The following is a description of a gene set: Reactome Pathway: G2/M Checkpoints part of: Cell Cycle Checkpoints studied in species Homo sapiens G2/M checkpoints include the checks for damaged DNA, unreplicated DNA, and checks that ensure that the genome is replicated once and only once per cell cycle. If cells pass these checkpoints, they follow normal transition to the M phase. However, if any of these checkpoints fail, mitotic entry is prevented by specific G2/M checkpoint events.<p>The G2/M checkpoints can fail due to the presence of unreplicated DNA or damaged DNA. In such instances, the cyclin-dependent kinase, Cdc2(Cdk1), is maintained in its inactive, phosphorylated state, and mitotic entry is prevented. Events that ensure that origins of DNA replication fire once and only once per cell cycle are also an example of a G2/M checkpoint.<p>In the event of high levels of DNA damage, the cells may also be directed to undergo apopotosis (not covered)., and this is the list of marker genes: CDC45 (cell division cycle 45), H2BC3, MCM3, H2BC9 (NCBI Gene Id 8345), RAD50, EXO1, PSMD11, H2BC13, H2BC21, ORC2, PSMC5, MCM8, MCM5 (NCBI Gene Id 4174), PSMB5, PSMB4, PSMA5, RPA1, CHEK1, ORC4, H2BC1, BRCC3, RFC3, PSMA4, PSMA6, MCM7, ORC3, TOPBP1, RMI1, CCNB1, RPS27A, PSMD3, H2AX, H2BC12L, ADRM1, MCM6, GTSE1, H2BC12, PSMB6, PSMB3, NBN, PSMD2, PSMC4, RNF168, CCNA1, MCM10, CDC6, H2BC5, PSMD12, PSMD8, TP53, YWHAH, RFC4 (NCBI Gene Id 5984), RBBP8, RFC5, H3-4, PSMD6, BABAM1, SFN, PSMD7, ATRIP, PSMB7, RAD17, CDK2, CCNB2, RPA2, TOP3A, H2BC17, ATM, PSMD1, MCM2, RMI2, PSMC3, CDK1, ORC6, MDC1, CCNA2, WEE1, PIAS4, MRE11, UBC, YWHAZ, PSMD13, BARD1, MCM4, ATR, UIMC1, BRCA1, H2BC11, H4C1, PSMA7, HUS1, RAD1, ORC5, CDC25C, CLSPN, UBE2V2, PSMC2, UBA52, H2BC4, UBE2N, PSMB2, H2BC26, RNF8, CDC25A, YWHAG, YWHAE, RHNO1, BABAM2, WRN, KAT5, RFC2, RPA3, NSD2, YWHAB, RAD9B, RAD9A, TP53BP1, PSMA3, PSMC6, YWHAQ, ORC1, SEM1, CDC7, H2BC15, PSMA2, PSMC1, DBF4, BRIP1, H2BC14, UBB, CHEK2, PSMD14, PSMA1, HERC2, PSMB1, DNA2, ABRAXAS1, PKMYT1, BLM